Given this list of marker genes FXN, MT-CYB, UQCR11, UQCC1, LYRM4, HSCB (HscB mitochondrial iron-sulfur cluster cochaperone), UQCC5, UQCRQ, HSPA9, UQCRB, ISCU, TTC19, NFS1, UQCRFS1, UQCC2, LYRM7, UQCC6, LETM1, UQCRC1, CYC1, UQCRH, UQCRC2, UQCR10, UQCRHL, UQCC3, BCS1L, here is a description of the gene set: studied in species Homo sapiens Human Gene Set: REACTOME_COMPLEX_III_ASSEMBLY Complex III assembly